The following is a description of a gene set: species: Homo sapiens Reactome Pathway: Digestion of dietary carbohydrate part of: Digestion Carbohydrate is a major component of the human diet, and includes starch (amylose and amylopectin) and disaccharides such as sucrose, lactose, maltose and, in small amounts, trehalose. The digestion of starch begins with the action of amylase enzymes secreted in the saliva and small intestine, which convert it to maltotriose, maltose, limit dextrins, and some glucose. Digestion of the limit dextrins and disaccharides, both dietary and starch-derived, to monosaccharides - glucose, galactose, and fructose - is accomplished by enzymes located on the luminal surfaces of enterocytes lining the microvilli of the small intestine (Van Beers et al. 1995)., and this is the list of marker genes: AMY2A, AMY1C, LCT, AMY2B, AMY1A, TREH (NCBI Gene Id 11181), MGAM, CHIA, SI, AMY1B, CHIT1